Given this list of marker genes SLC33A1, ST3GAL2, B3GALT1, ST3GAL1, FUT1, ST3GAL5, ST8SIA5, B4GALNT1, A3GALT2, B3GALT4, ST6GALNAC6, ST8SIA3, ST8SIA1, here is a description of the gene set: Ganglio sphingolipid metabolism Human Gene Set: WP_GANGLIO_SPHINGOLIPID_METABOLISM studied in species Homo sapiens